Given this list of marker genes Nup205, H2ac18, H4c18, H4c3, H3c7, H2aj, H2ac10, Sec13, H4c16, Rab1b (NCBI Gene Id 76308), H2bc11, H3c15, Lmna, Plk1, H2ab1, H3f4, H3f3b, Emd, H2bc6, Ncapg2, Rae1, Banf1, H4c8, Nup37, Rb1, Ranbp2, Vrk1, H2ab3 (NCBI Gene Id 635841), H2ac15 (NCBI Gene Id 319169), Nup93, H2bc12, H4c2, Nup153, H4c1, H2ac23, H2bc21, Rab1a, H3c10, Nup58, H3c2, H2ac19, Vrk2, Ncapd3, H2bc26, H4c6, H2ab2, H2ac12, Aaas, Nup155, H2ac22, H2bc8 (H2B clustered histone 8), Nup50, H4c12, Numa1, Mastl, H2ac7 (NCBI Gene Id 319165), H4c11, H3c8 (NCBI Gene Id 97908), H2ac11, Tpr, Pom121, H2bc14, Mapk3, Nup133, H2ac4, Gorasp1, Nup98, Mcph1, H2ac24, Nup54, Smc2, Ctdnep1, Gorasp2, Rbm39, Nup85, Cnep1r1, H2bc22, Ccnb1, H4c4, H3c11, Nup88, H2bc7, Nup210, H4c9, Smc4, H2bc13, Seh1l, Lpin2, Set, H2az2, H2ac6, H3c3, H2bc3, Lpin3, Lmnb1, Arpp19, Nup35 (nucleoporin 35), Nup62, Cdk1, H2ac8, H2ac20, Nup42, Blzf1, Prkcb, H3c4, H3f3a (H3.3 histone A), H2ac13 (NCBI Gene Id 319191), Ncaph2, H4c14, Mapk1, H2ax, H3c14, Nup188, H2bc9, Ccnb2, Nup43, H2bc15 (H2B clustered histone 15), Nek9, H2bc1, Ndc1, Nup107, H3c1, Nup214, H2bc4, H4c17, Rab2a, Golga2, Nup160, H3c13, H2bc24, H3c6, H2bc23, here is a description of the gene set: species: Mus musculus Mitotic Prophase Mouse Gene Set: REACTOME_MITOTIC_PROPHASE